The following is a description of a gene set: species: Mus musculus Mouse Gene Set: REACTOME_INNATE_IMMUNE_SYSTEM Innate Immune System, and this is the list of marker genes: Lpo, Ighv6-7, Copb1, Ighv3-8, Yes1, Ahsg, Arpc1b, Igkv8-21, Rap2c, Defa35, Kcnab2, Sos1, Rab3d, Igkv2-137, Siglec15, Arpc3, Mapk1, Atp6v1d, Tank, Gyg1 (NCBI Gene Id 99787), Gsdme, Map3k14, Irak2, Psg22, Defa28, Defa41 (defensin, alpha, 41), Igkv16-104, Dgat1, Serpina3f, Ripk3, Igkv1-131, Gaa, Defb18, Aamp (angio-associated migratory protein), Sting1, Fos, Leap2, Lpcat1 (NCBI Gene Id 97903), Dync1li1, Calm1, Defa32, C1qb, Ptafr, Ddx3x, Calm4, Baiap2, Ighv5-2, Cstb, Ms4a2, Rab14 (NCBI Gene Id 99047), Sell, Mapkapk3, Ptpn4, Ighv5-12-4, Pglyrp2 (NCBI Gene Id 623596), Atox1, Txndc5, Psmb4, Ighv5-16, Defb43, Nbeal2, Pigr, Cant1, Cd63, Wasf2, Ly96, Raf1, Skp1, Psmd3, Sarm1, Cfhr1, Rps6ka1, Acp3, Prdx4, Cdc34, Ticam2 (NCBI Gene Id 225471), Dnajc13, Ighv7-2, Mapk11, Abca13, Pin1, Cyfip2, Ubb, Psmd13, Ager, Rap1a, Pfkl, P2rx1, Atp11b, H2-M10.6, C8g, Aoc1, Pafah1b2, Defb21, Pgrmc1, Adgrg3, Slc44a2, Hrnr, Ighv8-9, Nkiras1, Cd247, Folr2, Psmc1, Ceacam1, Tom1, Cd46, Stom, Dock1, Prkaca, Pgm1, Alox5, Psmb6, Lcn2, H2-Q1, Pygl, Prss3l, Adam10, Tcirg1, Cd33, H2-Q2, Plpp4, Ighv3-4, AY761185, Psmd8, Cxcl1, Capn1, Tlr7, Ptk2, Rela, Pkp1, Dusp3 (dual specificity phosphatase 3 (vaccinia virus phosphatase VH1-related)), Defa25 (NCBI Gene Id 13236), Apob, Rnaset2a, Myo10, Chuk, Defa27, Tspan14, Glipr1 (GLI pathogenesis related 1), Lrrc7, Itch, Aga, Psmd12 (proteasome (prosome, macropain) 26S subunit, non-ATPase, 12), Atp6v1c1, Plaur, Sftpa1, Tmbim1, Dusp4 (NCBI Gene Id 70236), Ubr4, Hmgb1, Ccr6, Atp6v1b1, Dnm1, Ighv5-4, Manba, Psma1, Bin2, Serpinb3c, Atp6v1a, Lgmn, Bcl2, Plcg1, Dtx4, Casp4, Ighv13-2, Defa36, Txnip, Gla, Atp6v1g2, Tlr6, Golga7, Olr1 (oxidized low density lipoprotein (lectin-like) receptor 1), Hpse, Masp2, Pglyrp1, Qpct, Aldoa, Atp6v0d1, Nfkbib (nuclear factor of kappa light polypeptide gene enhancer in B cells inhibitor, beta), Anpep, Igkv2-112, Fpr1, Mapk13, Hspa1b, Nfatc2, Arhgap9, Nkiras2, Olfm4, S100a1, Peli3, Psmc5, Atp6v1e2, Fabp5, Ncstn, Defa24, Cfb, Ighv3-6, Ddx41, Serpinb3b, Reg3a, Atp6v1c2, Ctsb, Anxa2, Atp6v0e2, Rab37, Nckap1l (NCK associated protein 1 like), Fcer1g, C8a, Pglyrp4, Cst3, Prss1l, Psmd7, Defa3, Ubc, Limk1, Ighv12-3, Adrm1, Apeh, Cct2, Faf2, C3, Cpped1, S100a9, Myd88, Map3k8, Slco4c1, Cxcr1, Rab4b (RAB4B, member RAS oncogene family), Actr1b, Man2b1, Dusp7, Cd81, Ypel5, Prtn3, Hsp90b1, Dynll1, Actb, Clec12a, Ctsa, Dynlt1c, Nos2, Psma4, Pa2g4, Ighv3-1, Cd68, Ighv8-6, Hras (Harvey rat sarcoma virus oncogene), Cd93, Irf5, Plcg2, Ighv5-12, Hc, Clec4n, Icam2, Arpc5, Wipf3, Prss2, Chga, Dera, Casp8, Ighv7-3, Cd180, Psma6, Abi2, Gsn, Aim2, Npc2, Nme2, Tlr2, Casp1, Adam8, Mndal, Tlr9, Rnase6, Defa20, Pik3c3, Ear10, Snap25, Mospd2, Flg2, Clec4d, Ptprj, Ighg3, Defb36 (NCBI Gene Id 266620), Malt1, Ighg1, Plpp5 (NCBI Gene Id 98644), Ctsh, Itgal, Pik3r1, Kpnb1, Defa2, Igkv1-117, Atp6v0a4, Map2k6, Serpinb10, Scamp1, Tab2, Serpinb3d, Cotl1, Elmo1, Usp18, Iqgap1, Gpi1, Ilf2, Ighv8-12, Ighv8-13, Pld2 (phospholipase D2), Trpm2, Actr3, Pirb, Ighv6-6, Defa39, Atg7, Enpp4, Psmd6, Prg2 (proteoglycan 2, bone marrow), Svs3a, Nos3, Vrk3, Atp6v1g1, Camp, Arpc2, Cd19, Bpifb4, Clec5a, Cd209a, Rab7, Atp6v1g3, F2, Atp6v0b, Cpn2, Src, Ighv6-4, Creb1, Cpb2, Ticam1, Pdpk1, Pgm2, Ighv5-6, Try4, Gm2a, Pld4, Igkv1-110, Ear14, Defa38, Grb2, Ncf4, Psmb7, C1qc, Atp6v1e1, Nfasc (NCBI Gene Id 269116), Map2k4, Ube2v1, Ap1m1, Nos1, Trem2, Tmem30a, Igkv1-132, Fpr2, Hsp90ab1 (NCBI Gene Id 98078), Dok3, Fgb (NCBI Gene Id 67908), Defa37, Rab5c, Stk10, Psmc6, Nfam1, Ighv6-5, Cnn2, Pycard, Defb30, Ighv8-2, H2-M10.2, Rock1, 1600012H06Rik, Asah1, Dynlt1a, Clu, B4galt1, C2, Dync1h1, Psmd11, Irf7, Mif, Ighv5-17, C5ar2, Art1, Bpifb2, Ear1, Tbc1d10c, Alpk1, Iglc2, Sirpa, Slc15a4, D1Pas1, Fcgr1, Rbsn, Slc2a3, Psmc4, Vav3, Igkv1-135, Mgst1, Epx, Actg1, Grn, Cfd, Hspa1a, S100b, H2-M9, Pstpip1, Lamp1, Fuca1, Ghdc, Cfp, Ncf1 (neutrophil cytosolic factor 1), Igkv11-125, Cd55, Cpne1, Mapk8, Eef1a1, Aprt, Tubb5, Abl1 (NCBI Gene Id 98922), Chrnb4, Arsb, Ormdl3, Atp6v0a2, Myo1c, Commd9, Lamtor3, Kir3dl1, Gzmm, Bcl2l1, Actr10, Nlrc5, Defb47, Cda, Crp, Tab3, Rac1, Bst1, S100a8, Rab18, Plau, Traf3, Reg3d, Pak2, Eppin (epididymal peptidase inhibitor), Birc3, Ighv3-5, Pygb, Gpr84, Irak1, H2-T23, Ube2d3, Rab5b, Atp8b4, Aldh3b1, Prkacb, Pkm, Psen1, Cdc42, Trim32, Igkv18-36, Ndufc2, Stat6, Lcp2 (NCBI Gene Id 16822), Dusp6, Krt1, Atp6v1f, Prss1, Il1b, Nod2, Ube2d1, Dynlt1f, H2-M10.3, Cd177, Prg3, Cpn1, Capza2, Degs1, H2-M10.4 (histocompatibility 2, M region locus 10.4), C7, Mapk10, Gm5150, Pld3, Ighg2c, Ighv8-4, Nlrp3, Prkcq, Atp7a, H2-M10.5, Kcmf1, Defb1, Fga, Ptprc, Pira2, Mapk14 (mitogen-activated protein kinase 14), Klrc3, Elmo2, Ano6, Defa31, Optn, Tnip2, Try10, Ftl2-ps, Syk, Ctsc, Psma2, Gns, Btk, Ighv5-15, Adgre5, Ncf2, Mapkapk2, Traf6, Vamp8, Rnaset2b, Alad, Svs3b, Tnfrsf1b, Csnk2b, Hsp90aa1, Gstp2, Cybb, Arhgap45, Dnase1l1, Ifi211, C8b, Defb25, Fcgr4, H2-Q4, Lyn, Ighe (Immunoglobulin heavy constant epsilon), Psmc3, Itgam, Abi1, Myh9, S100a11, Defb19, Cystm1, Atp11a, Myo5a, Nckap1, Igkv17-121, Hebp2, H2-M3, Dhx9, Dhx36, Cracr2a, Syngr1, Tollip, Impdh1, Hspa8, Defa34, Defa5, Pak3, Cyba, Gsdmd, Vapa, Atp6v1h, Pik3r2, Ube2n, Srp14, Lta4h, Txk, Myo9b, Cd300lb, Ggh, Map3k7, Pglyrp3, Gusb, Hp, Ppp2r1a, Iqgap2, Dnajc3, Eea1, Try5, Klrk1, Defa17, Slc27a2, Ctsk, Rps27a, Vcp, Neu1, Psmd2, Orm2, Cyld, Retn, Lamtor1, Pak1, Igkv1-35, Psma5, Tasl, Txn1, Pnp, Cand1, Vps35l, Psg29, Prcp, Nfkb2, Ripk2, Tax1bp1, Panx1, Rps6ka5, Ctss, Trem1, Fbxw11, Qsox1, Ly86, Arpc4, Ighv5-9, Ppp3cb, Nhlrc3, Lat, Rab31, Bst2, Ighv3-3, Nlrp4c, Casp9, Tarm1, Serpinb1a, Padi2, Wasf1 (WASP family, member 1), Arg1, Rab10, Ckap4, Igkv1-88, Usp14, N4bp1, Ist1, Ctnnb1, Mcemp1, Wasf3, Pecam1, Defa42, Atp6v0d2, Defa22, Tomm70a, Ikbkg, Trim56, Ep300, Eef2, H2-M10.1, Nfatc3, Stk11ip, Siglece, Fth1, Atad3a, Trappc1, Tbk1, Dock2, Rac2, Wipf1, Bpifa1, Xrcc5, C9, Lck, Casp2, Itgb2, Atp6v0e, H2-M2, Colec11, Tnfaip3, Brk1 (BRICK1, SCAR/WAVE actin-nucleating complex subunit), Tyrobp, H2-Q6, Ube2m, Itgax, Cfhr4 (NCBI Gene Id 214403), Hmox2, Idh1 (isocitrate dehydrogenase 1 (NADP+), soluble), Slc11a1, Mre11a, Defa23, Card11, Crk, Hvcn1, Vat1, Cd4, Arsa, Lilra5, Mapk12, Cxcr2, Atp6ap2, Gca, Lamp2, Dsn1, Atf2, Diaph1, Cd3g, 2310033P09Rik, Slpi (NCBI Gene Id 20568), Ctsl, Ms4a3, Nf2, Mmp8, Ighv8-8, Lilra6, Relb, Ppp2r1b, Snap29 (NCBI Gene Id 67474), Map2k7, Atp6v0a1, Surf4, Hk3, Snap23, Rab44, Mgam (maltase-glucoamylase), Elane, Ampd3, Atp6v0c, Bri3, Ppia, Tifa, Ptpn6, Itk, Cfh, Pdzd11, Nfatc1, Cd59b, Ikbkb, Tab1, Fuca2 (NCBI Gene Id 75741), Mapk9, Cfi, Psap, Cd14, Iglc1, Huwe1, Igkv15-103, Ube2d2a (ubiquitin-conjugating enzyme E2D 2A), Unc93b1, H2-T10, Arpc1a, Serpinb12, C5ar1, Sdcbp, Cyb5r3, Colec10, Serpina1c, Tlr4, Cd36, Ptges2, Tirap, Reg3g, Ppp3ca, Ear6, Vav2, Nfkb1, Chit1, Ifi204, Cmtm6, Prkcd, H2-K1, Crispld2, Cd44, Dnm2, Frk, Tmem179b, Vnn1 (vanin 1), Peli1, Mapk3, H2-Q10, Rap1b, Bcl10, Calm2, Ighv5-9-1 (immunoglobulin heavy variable 5-9-1), Tubb4b, Dnajc5, Ap2a2, Pira13, P2rx7, Dpp7, Ptprn2, Fcer1a, Cct8, Igkv2-109, Fadd, Pdap1, Vav1, A1bg, Nck1, Prss3, Igkv1-99, Siglecg, Fcnb, Apaf1, Pnp2, Ppbp, Lat2, Ctsz, Agpat2, Psmb5, Chi3l1, Ripk1, Pik3ca, Psmb2, Pdxk, Svip, Klrc1, Nit2, Aldoc (NCBI Gene Id 20285), Myh2, Uba3, Dsp, Ostf1, Rab3a, H2-M11, Stbd1, Fcna, Erp44 (endoplasmic reticulum protein 44), H2-M1, Defb14, Fyn, Grap2, Rab6a, Lrrc14, Plekho2, Rnase2b, Ptpn11, Acaa1b, Mvp, Cyfip1, Cd47, Tlr8, Ctsd, Pgam1, C3ar1, Orm1, Commd3, Ppp2r5d, Ear2, Mpo, Orm3, Lbp, Ptx3, Hexb, Agl, Tmem63a, Psmd14, Gmfg, Timp2 (tissue inhibitor of metalloproteinase 2), Serpina1b, Ighv7-4 (immunoglobulin heavy variable 7-4), Ppp3r1, Prdx6, C6, Igll1, Hgsnat, Hbb-bt, Cd300e, Atp8a1, Serpinb3a, Armc8, Traf2, Jup, Prkce, Dnm3, Bpifa2, Sptan1, App, Sftpd, Shc1, Ltf, Rap2b, Hbb-bs, Uba52, Mlec, Glb1, Tlr1, Itln1, Mmp25, Pik3cb, Psmb1, Pla2g2a, Psmd1, Uba52rt, Itgav, Atf1, Defa21, Rnase2a, Dsg1a, Pira12, Plac8, Ikbke, C1qa, Ighv8-5, Cpne3 (NCBI Gene Id 97175), Klrc2, Psma7, Acly, Nlrx1, Oscar, Cep290, Calm3, C4b, Irf3, Ddost, Sorbs2, Masp1, Unc13d, Ecsit, Gstp1, Defa43, Cdk13, Creg1, Defb28, Cd53, H2-T22, Dynlt1b, Xrcc6, Rab9b, Mme, Defa40 (NCBI Gene Id 100046107), Psg18, Ighv8-11, Magt1, Nlrp1a, Igkv20-101-2 (immunoglobulin kappa chain variable 20-101-2), Lamtor2, H2-M5, Ceacam2, Igkv1-122, BC051665, Psmb3, Nckipsd, Trim21, Ighv16-1, Fgg, Birc2, Actr2, Defa30, Cab39, Kras, Klrd1, Impdh2, Frmpd3, Bpifb6, Cat, Psma3, Nfkbia, Cr2, Sugt1, Rab27a, Pik3r4, Rhof, Nod1, Ptprb, Rhog, Igf2r (NCBI Gene Id 16004), Slc2a5, Defb48, Rab24, C1s2, Cul1, Bpi, Rigi, Atp6v1b2, Peli2, Card9, Ppp2ca, Dsc1, Lyz2, Vtn, Lair1, Igkv1-133, Defa29, Mefv, Ighv6-3, Pla2g6, Clec4e, Gdi2, Psmc2, Fcgr2b, Ifi205, Defb42, Ttr, B2m, Naprt, Jun, Cap1, Tmc6, Mbl2, Mapk7, Mavs, Rps6ka2, Reg3b, Vcl, Rps6ka3, Defb4, Fgl2, Kir3dl2, Cd300c2, Ppp2cb, Hck, Rhoa, H2-Q7, Serping1, Cnpy3 (NCBI Gene Id 73685), Defa26, Tnfaip6, Fgr, Mmp9, Map2k3, Bpifb1, Serpinb6a, Galns, C1ra, Ctsg, Arl8a